The following is a description of a gene set: studied in species Mus musculus Any process that stops, prevents, or reduces the frequency, rate or extent of the assembly of actin filament bundles. Mouse Gene Set: GOBP_NEGATIVE_REGULATION_OF_ACTIN_FILAMENT_BUNDLE_ASSEMBLY, and this is the list of marker genes: Phldb2, Dbn1, Rhpn2, Tmsb15l, Kank2, Myoc, Pak2, Kank3, Arap1, Rhpn1, Stmn1, Arhgap28, Cfl1, Shank3, Dlc1, Prkn, Frmd7, Cgnl1, Was, Ppp1r9a, Tmeff2, Arhgap6, Pik3r1, Met, Shank1, Tmsb15b2, Kank4, Clasp1, Pfn1, Tjp1, Map3k1, S1pr1, Ppfia1, Inpp5k, Coro2b, Arhgef18, Wasf2, Tacstd2, F11r, Clasp2